Given this list of marker genes PDK4, PCK1, JUN, STAT3, GPAM (glycerol-3-phosphate acyltransferase, mitochondrial), PPARA, NR0B2, CYP1A2, ESR1, SP1, CYP1B1, CYP1A1, ACOX1, here is a description of the gene set: Human Gene Set: WP_ESTROGEN_RECEPTOR_PATHWAY Estrogen receptor pathway species: Homo sapiens